Given this list of marker genes ZNF844, ZFAND4, TDRD1, SLC2A13, RNF128, MCMDC2, BMERB1, ZNF704, DPYSL3, APLP2, KDM5A, ATP2B2, NREP, MORC3, PTPRB, ABL2, POLR3K (NCBI Gene Id 51728), ADGRA2, TRAM2, PPP1R3B, SLC4A7, KMT5A, COQ10A, RALBP1, ENAM, LINC03103, OSBPL3, SCAI, GLCCI1, PDE1C, SH3BGR, ALDH9A1, WNK1, COL1A2, PSMA4, CCDC80, FGF2, RBMS3 (RNA binding motif single stranded interacting protein 3), NR4A1, NTRK3, PCDH9, ANAPC1, FAF2 (Fas associated factor family member 2), IL24, GPR107, LINC03042, AHR, TGM6, ATXN1, TAGAP, SRARP, MOG, IGSF9B, KLHL9, WWP1, CWC27, ALG10B, CREBRF, HLA-DRB5, CHD5, LRIG1, CKLF, ITGA2, ZFX, DGKH, ACADSB, GATAD2B (NCBI Gene Id 57459), RMI1, PPP1R2, MAP1B, ARID4A, VNN1, LPP, C5orf63, FOXN3, RFC1, ZNF440, RPS6KB1, TIPARP, AMT (aminomethyltransferase), TMEM26, AKAP3, CNTNAP3B, GALE, MEOX2, EPC1, ZDHHC3, EPM2A (EPM2A glucan phosphatase, laforin), PCMT1, RAB2B, TLNRD1, GET1-SH3BGR, TMLHE, PDE7A, PICALM, NIPSNAP2, CDH8, GEN1, ATRX, OXR1, HNRNPLL, GNAS, ZFP36L1, PRMT2, FCHSD2, EPPIN, CAMTA1, SERTAD3, SNX20, MEI4, PLCB1, CARHSP1, GPR137, CKAP4, MCC, FUT9, FAM110B, NEIL1, HPN, CCDC28A, DUOX2 (NCBI Gene Id 82430), KIAA0930, ARPP19, TMT1B, here is a description of the gene set: Human Gene Set: MIR3190_3P from publication Chen Y, Wang X (PMID 31504780) studied in species Homo sapiens Genes predicted to be targets of miRBase v22 microRNA hsa-miR-3190-3p in miRDB v6.0 with MirTarget v4 prediction scores > 80 (high confidence targets).